The following is a description of a gene set: species: Homo sapiens Genes up-regulated in primary keratinocytes by expression of constantly active NOTCH1. Notch signaling promotes commitment of keratinocytes to differentiation and suppresses tumorigenesis. p63, a p53 family member, has been implicated in establishment of the keratinocyte cell fate and/or maintenance of epithelial self-renewal. Here we show that p63 expression is suppressed by Notch1 activation in both mouse and human keratinocytes through a mechanism independent of cell cycle withdrawal and requiring down-modulation of selected interferon-responsive genes, including IRF7 and/or IRF3. In turn, elevated p63 expression counteracts the ability of Notch1 to restrict growth and promote differentiation. p63 functions as a selective modulator of Notch1-dependent transcription and function, with the Hes-1 gene as one of its direct negative targets. Thus, a complex cross-talk between Notch and p63 is involved in the balance between keratinocyte self-renewal and differentiation. Human Gene Set: NGUYEN_NOTCH1_TARGETS_UP from publication Nguyen BC, Lefort K, Mandinova A, Antonini D, Devgan V, Della Gatta G, Koster MI, Zhang Z, Wang J, Tommasi di Vignano A, Kitajewski J, Chiorino G, Roop DR, Missero C, Dotto GP (PMID 16618808), and this is the list of marker genes: PCF11, LAMB2 (laminin subunit beta 2), CD4, ABCC8, RBP1, ANXA6, COL18A1 (collagen type XVIII alpha 1 chain), PHB2, SEC62, TCAP, STAT5A, SLC4A3 (solute carrier family 4 member 3), SLC12A3, HDAC1, ARL6IP5, FLOT1, PTHLH, CNTN1, BRCA1, HMGCR, SFPQ, ITGAV, COL4A6, TAGLN, S100A13, CANX, F2R (NCBI Gene Id 2149)